Given this list of marker genes Psmc5, H4c14, Psma4, H2bc9, Twist1, Stt3a, Actc1, H2ac1, Psma1, Dad1, H3c6, H2bc13 (H2B clustered histone 13), H2ac24, Csnk2b, H2ac7, Actg2, Smarca4, H4c8, H2ac8 (H2A clustered histone 8), Acta1, H2bc12, Psmd6, H2bc8, H2ac13, H2ac19, Banp (NCBI Gene Id 53325), Psmd13, H3c7, Psmd1 (NCBI Gene Id 70247), Psmb5, H2ac4, Psmc1, Ctss, H2ax, Psmc4, Spcs1, H2ac20 (NCBI Gene Id 319176), Dnm2, H2ac11, Kdm1a, H3c15, Pomt2, Tmem258, H4c17, Psma3, H3c1, H2bc3, Spcs3, Psmb7 (NCBI Gene Id 19177), H4c12, Ctnnb1, Psmb6, H2bc15, Ubb, Psma6, H3c4, Psmd12, Psma2, H2ac22 (H2A clustered histone 22), H2bc11, H2bc27, H2ac23, Mtbp, Psma7, Spcs2, H4c3, Psmc6, Dnttip1, Pip5k1c, Cdh1, Zmym2, H2az2, Psmc3, Psmd7, H3c2, H2ac12, H2bc1, Psma5, H3c10, H4c11, Prkcsh, Psmc2, H4c2, Rps27a, Pomt1, Ganab, H4c18 (H4 clustered histone 18), Cbll1, H3f3a, Ost4, Jup, H3c13, H4c4, Rack1 (receptor for activated C kinase 1), Pcsk7, H2ac6, H4c6, Rbbp7, H2bc7, H2ac10, H2ac15, H3c3, Fyn, Rbbp4 (retinoblastoma binding protein 4, chromatin remodeling factor), Psmb4, H4c9, Ddost, H3c11, H2bc22, Sec11c (SEC11 homolog C, signal peptidase complex subunit), H3c8, Ezh2, H4c1, here is a description of the gene set: This event has been computationally inferred from an event that has been demonstrated in another species.<p>The inference is based on the homology mapping from PANTHER. Briefly, reactions for which all involved PhysicalEntities (in input, output and catalyst) have a mapped orthologue/paralogue (for complexes at least 75% of components must have a mapping) are inferred to the other species. species: Mus musculus Reactome Pathway: Regulation of CDH1 Expression and Function part of: Regulation of Expression and Function of Type I Classical Cadherins electronically inferred by orthology from the curated human pathway